Given this list of marker genes CIAO2A, CIAO3, CIAO1, MMS19, CIAO2B, here is a description of the gene set: species: Homo sapiens Human Gene Set: GOCC_CYTOSOLIC_4FE_4S_ASSEMBLY_TARGETING_COMPLEX A protein complex capable of condensing two 2Fe-2S clusters into one 4Fe-4S center in the cytoplasm and nucleus. In humans it consists of MMS19, CIAO1, CIAO2A/CIAO2B, CIAO3. MMS19, CIAO1 and CIAO2A/CIAO2B form a tight 'core' complex, whereas CIAO3 is an 'external' component of this complex.